The following is a description of a gene set: The multiplication or reproduction of hepatic stellate cells, resulting in the expansion of a hepatic stellate cell population. Hepatic stellate cells are found in the perisinusoidal space of the liver, and are capable of multiple roles including storage of retinol, presentation of antigen to T cells (including CD1d-restricted NKT cells), and upon activation, production of extracellular matrix components. This cell type comprises approximately 8-15% of total cells in the liver. studied in species Mus musculus Mouse Gene Set: GOBP_HEPATIC_STELLATE_CELL_PROLIFERATION, and this is the list of marker genes: Pdgfb, Dicer1, Ddr2, Socs1, Kcnn4 (potassium intermediate/small conductance calcium-activated channel, subfamily N, member 4), Myb